The following is a description of a gene set: After activation, CD4+ helper T (Th) cells differentiate into distinct effector subsets. Although chemokine (C-X-C motif) receptor 5-expressing T follicular helper (Tfh) cells are important in humoral immunity, their developmental regulation is unclear. Here we show that Tfh cells had a distinct gene expression profile and developed in vivo independently of the Th1 or Th2 cell lineages. Tfh cell generation was regulated by ICOS ligand (ICOSL) expressed on B cells and was dependent on interleukin-21 (IL-21), IL-6, and signal transducer and activator of transcription 3. However, unlike Th17 cells, differentiation of Tfh cells did not require transforming growth factor b (TGF-b) or Th17-specific orphan nuclear receptors RORa and RORg in vivo. Finally, naive T cells activated in vitro in the presence of IL-21 but not TGF-b signaling preferentially acquired Tfh gene expression and promoted germinal-center reactions in vivo. This study thus demonstrates that Tfh is a distinct Th cell lineage. species: Homo sapiens Human Gene Set: GSE11924_TFH_VS_TH1_CD4_TCELL_UP from publication Nurieva RI, Chung Y, Hwang D, Yang XO, Kang HS, Ma L, Wang YH, Watowich SS, Jetten AM, Tian Q, Dong C (PMID 18599325) Genes up-regulated in comparison of T follicular helper (Tfh) cells versus Th1 cells., and this is the list of marker genes: MX2 (NCBI Gene Id 4600), IFIT3, TRRAP, DPY19L3, CTSG, IPMK, B4GALT1, ATXN7L3, ALKBH6, POLR2A (NCBI Gene Id 5430), PGAP6, WDTC1, ACAP2, CASP4, NDRG3, NAIF1, SETDB2, STRADA, TCIRG1, ZNF408, ARNT, MBD1, WBP1, EMSY, ERBB3, SEC22C, MAPK8, ARAP1, AGTPBP1, NBR1, PPM1K, TADA3, DCP1B (NCBI Gene Id 196513), ASAH2, CNEP1R1, FAM53C, TRIR, ABI1 (NCBI Gene Id 10006, abl interactor 1), ORAI2, MACC1, ATP2B1, MYH9, TBC1D22A, PCMTD1, RIC1, UNC45A, ASB3, HNRNPUL1, B3GALT4, ARID4A, POLG2, CAPZB, CNOT4, SUN2, CCNT1, DIS3L2, ZFTRAF1, CSPP1, LYN, TDRD3, CD6, IGF1R, CEP83-DT, VAMP2, CRBN, PEAR1, ANXA3, CABLES2, CRMP1, HIPK2, RAVER1, KCTD18, GNG4, ICAM2, TMEM50A, RPH3AL, MAEA, MAP3K14, APOE, OAS1, ST8SIA1, SPRED2, RNPEPL1, GPR108, CHD8, SP1, ATG10, CHIC1, ARPC3, RC3H2, BRAF, CEP97, LTB, ZFYVE1, TPR, MFAP3, SFI1, GPR137 (G protein-coupled receptor 137), HIGD2A, BTBD6, APLP2, SLC35A5, UAP1L1, SECISBP2L, FAM110A, NEURL4, MON1B, BCL2A1, ZFAND2A, GBA2, ACCS, RAPGEF6, USP21, SUOX, ZNF646, NPNT, TOR3A, CPE, ABHD8, CHMP1B, MYL6, GALNT2, RAB33B, ACTR3, ZSCAN26, UGCG, MAN1C1, SLU7, AGPAT1, SMTN, CCDC97 (NCBI Gene Id 90324), OSBPL3, AKAP5, TTLL3, MCM9, KMT2D (NCBI Gene Id 8085), MCM3AP, PEX26, SLK, PEF1, VRK3, NFIA, APOBEC1, ZNF384, DNTTIP1, FHIP1A, MCOLN1, CHD1, CARF, GBP4, ZBTB48, ANGPTL1, SPATA2, CXorf38, CCDC12, KIF13B, PQBP1, DCLK2, TTC33, MRGBP, MEST, SEC24B, RFX3, CORO1A, CCDC82, CAST, IQGAP1, OPA3, FHIT, RANBP10, ZNF551, SF1, LGMN, NDUFAF3, MAP4K3, GNAI3, CREBBP, ACP3, WWOX, GADD45A, AGRN, SUFU, RBM39, BAG3, ICOSLG, NMRK1, PINK1, RDH5, RILPL2, TBC1D1, GPR84 (NCBI Gene Id 57098), SCAF8, USP3, CCS, PTPRO, SLC9A8, AP4E1, CBX4, MAP2K7